The following is a description of a gene set: Mouse Gene Set: CUI_B_CELL_GM_CSF_RESPONSE_UP Genes positively differentially expressed in cell type: B cell upon treatment with cytokine: GM-CSF in mouse lymph nodes in vivo. species: Mus musculus Cytokines mediate cell-cell communication in the immune system and represent important therapeutic targets. A myriad of studies have highlighted their central role in immune function, yet we lack a global view of the cellular responses of each immune cell type to each cytokine. To address this gap, the authors created the Immune Dictionary, a compendium of single-cell transcriptomic profiles of more than 17 immune cell types in response to each of 86 cytokines (>1,400 cytokine-cell type combinations) in mouse lymph nodes in vivo. A cytokine-centric view of the dictionary revealed that most cytokines induce highly cell-type-specific responses. For example, the inflammatory cytokine interleukin-1β induces distinct gene programmes in almost every cell type. A cell-type-centric view of the dictionary identified more than 66 cytokine-driven cellular polarization states across immune cell types, including previously uncharacterized states such as an interleukin-18-induced polyfunctional natural killer cell state. from publication Cui A, Huang T, Li S, Ma A, Pérez JL, Sander C, Keskin DB, Wu CJ, Fraenkel E, Hacohen N (PMID 38057668), and this is the list of marker genes: Uxt, Gbp3, Sec11a, Psma7 (NCBI Gene Id 26444), Agfg1, Pole4, Manf, Taf10, Adh5, Gnptg, Senp2, Eif1ad, Tpd52l2 (NCBI Gene Id 99179)